The following is a description of a gene set: Human Gene Set: REACTOME_GAB1_SIGNALOSOME species: Homo sapiens GAB1 signalosome, and this is the list of marker genes: PTPN11, SRC, CSK, PIK3R1, EPGN, EGF, BTC, GRB2, HBEGF (heparin binding EGF like growth factor), GAB1, EGFR, PAG1, PXN (paxillin), PIK3CA, AREG, TGFA, EREG